The following is a description of a gene set: Genes up-regulated in dendritic cells: untreated versus 2h after infection of Leishmania major. Human Gene Set: GSE42088_UNINF_VS_LEISHMANIA_INF_DC_2H_UP from publication Favila MA, Geraci NS, Zeng E, Harker B, Condon D, Cotton RN, Jayakumar A, Tripathi V, McDowell MA (PMID 24808365) studied in species Homo sapiens Leishmania major infected human dendritic cells (DCs) exhibit a marked induction of IL-12 ultimately promoting a robust Th1-mediated response associated with parasite killing and protective immunity. In this study, we utilized Affymetrix Genechips to globally assess the host cell genes and pathways associated with L. major infection during early infection (2, 4, 8, and 24 hrs) in human myeloid-derived DCs. Bioinformatic analyses of the hybridized microarray chips identified genes, represented by 848 unique probe sets, which, when compared to uninfected samples were observed to be significantly differentially expressed by one-way ANOVA. Altogether, the data provide a genome-wide perspective on the transcriptional influences Leishmania species exert within human DCs during early infection, and provides a platform for further investigations toward functionally characterizing candidate genes of importance to the IL-12 based immune response to infections. In the current study, we further investigate the L. major infected DC transcriptional during early time points after infection via microarray analysis., and this is the list of marker genes: CLIC2, UST (uronyl 2-sulfotransferase), HSPD1, POLD2, TXNRD1, NF1, ADRM1, MREG, IGSF3, ATXN1, IL15RA, SEC61A1, PPP6R2, RHOBTB3, HSP90AB1, MT1X, PDE4DIP, IDO1, RAB13, DNAJB9, PUS7, MAP3K4, RRP1, GSDME (NCBI Gene Id 1687), STK26, CXCL5, CEP135, TBC1D13, RPS6KC1, AK4, FLT1, AMIGO2, ELOA, SDF4, CHST2, ACSL5, HRH1, IL24 (interleukin 24), CD44, NFE2L1, ETNK1, TNIP3, MYO1E, FSCN1, CSF2, MICALL1, MMP1, STIP1, MT2A, PSMA6, ZNF804A, METTL1, PUM3, PSMA7, PLGRKT, SINHCAF, DNPH1, PSMA3, STAM2, BET1, GDI1, TNFRSF4, KIF3B, PLXNA1, TFPI, MMP10, MTHFD2L, ARL1, WSB2, CYP27B1, VCP, C3, SERPINB7, IL6, IL12B, ADAMDEC1, MICA, HSPA8 (heat shock protein family A (Hsp70) member 8), MT1H, MAP3K5, JAKMIP2, LAMP3, PRPF3 (NCBI Gene Id 9129), YRDC, TNFSF15, FAM135A, UBFD1, SPRING1, MYDGF, EVA1B, PRR16, MT1E, LRRC59, NME1, IL19, SLAMF7, MT1F, CXCL1, GRB10, MGLL, GMPPB, CFLAR, LSS, EBI3, ACO1, GFPT1 (glutamine--fructose-6-phosphate transaminase 1), CRIM1, PAICS, DDX10, CUL4A, ST3GAL2, PSMD1, MRTO4, SPATS2L, FKBP4, DESI1, MATK, ENTPD7 (NCBI Gene Id 57089), POLR3D, RDX, CDK14 (cyclin dependent kinase 14), PCID2, ITGB8, EHF, EXOSC7, TP53BP1, BATF, SLC1A3, ZNF767P, MSC, AKT3 (AKT serine/threonine kinase 3), LRP12, SLC11A2, HSPE1, CYP3A5, CXCL6, PSMA5, CSF3, LYRM1, GART, NDP, ANXA5, PDSS1, INHBA, MSMO1, GPR137B, CASP7, TTC4, RTN2, SOCS3, BYSL, C1QTNF1, NIBAN1, HEY1 (NCBI Gene Id 23462), CXCL8 (C-X-C motif chemokine ligand 8), GLRX3, PSAT1, IL2RA, HNRNPC, FERMT2 (FERM domain containing kindlin 2), IL36G, AGTR2, MT1G, PRDX1, IPO5, NUP188, CSTB, MMP14, SPINK1, AGK, MT1HL1, TFPI2, IL23A, RBM19, ATP6V1H, TRIP10, KEAP1, TXN, PSD3, AHSA1, NMB, FICD, MINDY3 (MINDY lysine 48 deubiquitinase 3), SNX16 (sorting nexin 16), PKNOX1, PPP3CC, PTPRJ (NCBI Gene Id 5795), HDAC9, TRAPPC4, AMPD3, RCN1, SEC61G, CLGN, PGM3, AGRN, NRBP1, PLAT, MRPL52, SOS1, ATP2C1